The following is a description of a gene set: studied in species Homo sapiens Pathway Definition from KEGG: RELN -> VLDLR == DAB1 -> PI3K -> PIP3 -> AKT -| (TSC1+TSC2) -| RHEB -> MTOR -> S6K RELN-VLDLR-PI3K signaling pathway. Pathway ID: N00963. Pathway type: Reference. Pathway class: nt06462 Spinocerebellar ataxia. Human Gene Set: KEGG_MEDICUS_REFERENCE_RELN_VLDLR_PI3K_SIGNALING_PATHWAY, and this is the list of marker genes: TSC2, RPS6KB1, MTOR, AKT2, VLDLR, PIK3CA, RPS6KB2, PIK3CB, AKT3, AKT1, DAB1, RELN, TSC1, PIK3CD, RHEB